Given this list of marker genes ALOX15, ALOX12, PTGR1, CYP4F3, ALOX15B, here is a description of the gene set: Human Gene Set: GOBP_LIPOXIN_A4_METABOLIC_PROCESS The chemical reactions and pathways involving lipoxin A4. Lipoxin A4 is a C20 hydroxy fatty acid having (5S)-, (6R)- and (15S)-hydroxy groups as well as (7E)- (9E)-, (11Z)- and (13E)-double bonds. studied in species Homo sapiens